The following is a description of a gene set: Human Gene Set: NAKAYA_PBMC_FLUARIX_FLUVIRIN_AGE_18_50YO_CORRELATED_WITH_HAI_28DY_RESPONSE_AT_7DY_POSITIVE Here we have used a systems biology approach to study innate and adaptive responses to vaccination against influenza in humans during three consecutive influenza seasons. We studied healthy adults vaccinated with trivalent inactivated influenza vaccine (TIV) or live attenuated influenza vaccine (LAIV). TIV induced higher antibody titers and more plasmablasts than LAIV did. In subjects vaccinated with TIV, early molecular signatures correlated with and could be used to accurately predict later antibody titers in two independent trials. Notably, expression of the kinase CaMKIV at day 3 was inversely correlated with later antibody titers. Vaccination of CaMKIV-deficient mice with TIV induced enhanced antigen-specific antibody titers, which demonstrated an unappreciated role for CaMKIV in the regulation of antibody responses. Thus, systems approaches can be used to predict immunogenicity and provide new mechanistic insights about vaccines. Genes positively correlated with HAI response at 28d in peripheral blood mononuclear cell in adults (18-50) after exposure to Fluarix/Fluvirin, time point 7D. Comment: Supplementary Table 5: All genes whose expression (d3/d0 or d7/d0) correlates to the fold increase in HAI titers (d28/d0). from publication Nakaya HI, Wrammert J, Lee EK, Racioppi L, Marie-Kunze S, Haining WN, Means AR, Kasturi SP, Khan N, Li GM, McCausland M, Kanchan V, Kokko KE, Li S, Elbein R, Mehta AK, Aderem A, Subbarao K, Ahmed R, Pulendran B (PMID 21743478) studied in species Homo sapiens, and this is the list of marker genes: SLX1B, ZNF124, POU2AF1, UQCRQ, RNF31, CRELD2, CD59, CTNNA1, KIAA2013, CXCR1, UBXN2B, IGLC1 (NCBI Gene Id 3537), IGKV1D-33, NFIB, TXNDC5 (thioredoxin domain containing 5), PALLD, ERLEC1, CKLF, INKA2, IGKV3-20, CLPTM1L, IGLL1, GGH, TIMM8B, PLPBP, DNAH1, SRPK1, SEMA4A, PDIA4, RPS27L, PLPP5, SLC17A9, TXNDC15, CALML4, IGLV3-16, CD38, MYDGF (NCBI Gene Id 80302), VRK3, FGD4, SIGLEC10, MLEC, IGKC, IGHG4, NDUFB6 (NCBI Gene Id 4712), KCNJ2, MZB1, RPN1, GP1BB, MESD, SIGLEC12, MFSD12, SLC35B1 (NCBI Gene Id 10237), ITPK1, NOMO2, NOMO1, CAV1, SHMT2, CARHSP1, ACO2 (NCBI Gene Id 50), CSF1R, TMEM258, IGHA1, PDIA6, EMC1 (NCBI Gene Id 23065), LRP10, KDELR2, CR1, ATP6V1A, GEMIN7, PPCDC, SFT2D1, DGAT2, SRPRA, IGLV1-44, ENTPD1, RRM2, BLOC1S5 (NCBI Gene Id 63915), MORN1, SLX1A, CCPG1, SEC11C, AP3S2, UBE2J1, SSR1, EYA3 (EYA transcriptional coactivator and phosphatase 3), MAP2K4 (NCBI Gene Id 6416), BTK, STOX2, RPN2, SLAMF7, ARAP3, HSP90B1, EMSY, MCCC2, IGHD, IGHG3, ATP1B3, CHCHD1, SEC24D, TRAC, DAPK1, FNDC3B, PLCG2, P4HB, PRDX3, NDUFB3, TYMS, FLOT1, MRPL51, CCDC18, MANF, SLC44A1, SNRNP25, ORMDL2, S100A11, IGHM, NOMO3, IGLL5, RHOG, UGGT1, CENPW, PSMD14, TMEM165, UQCC3, SLC38A10, ZWINT, CHERP, MAN1A1, CIDEB, AURKAIP1, WNK2, RUNX1, EAF2, UBE2C, TMT1A, PRDX1, PITPNA, NIPSNAP1, IGHV4-31, SCAMP2, TP53INP1, SPCS2, SLC30A1, IGLV3-25, IGHG1 (NCBI Gene Id 3500), CREB3L2, CLMN (calmin), PECAM1, HYOU1, IGHA2, CD93, PNOC, CCNA2, RBM26, OPCML (NCBI Gene Id 4978), APOBEC3B, TNFRSF17, CLC, MANEA, HDLBP, TMEM176A (transmembrane protein 176A), PDXK